The following is a description of a gene set: studied in species Homo sapiens Human Gene Set: GOBP_REGULATION_OF_LIPOPROTEIN_METABOLIC_PROCESS Any process that modulates the frequency, rate or extent of the chemical reactions and pathways involving lipoproteins, any conjugated, water-soluble protein in which the nonprotein group consists of a lipid or lipids., and this is the list of marker genes: LEP, RAB3GAP2, PIK3C3, APOD (apolipoprotein D), ITGB3, RABL3, DBI, LIPG, DGAT2, HHATL, RAB3GAP1, ITGAV, SVIP, ANGPTL8